The following is a description of a gene set: Human Gene Set: GOBP_REGULATION_OF_ARGININE_METABOLIC_PROCESS Any process that modulates the frequency, rate or extent of the chemical reactions and pathways involving arginine, 2-amino-5-(carbamimidamido)pentanoic acid. species: Homo sapiens, and this is the list of marker genes: FH, MIR21, CLN3, SLC7A7, ATP2B4